The following is a description of a gene set: studied in species Mus musculus Mouse Gene Set: GOBP_COCHLEA_DEVELOPMENT The progression of the cochlea over time from its formation to the mature structure. The cochlea is the snail-shaped portion of the inner ear that is responsible for the detection of sound., and this is the list of marker genes: Ptk7, Grhl3, Hey2, Hpn, Slc17a8 (solute carrier family 17 (sodium-dependent inorganic phosphate cotransporter), member 8), Neurog1, Kcnk2, Pafah1b1, Fgfr3, Vangl2, Grxcr1, Pou3f4, Gabrb3, Pax2, Ccna2, Cecr2, Cdh1, Hoxa1, Sox9, Myo3b, Gabrb2, Dvl3, Gata2 (NCBI Gene Id 14461), Cdh23, Calb1, Slitrk6, Hes1, Zeb1, Dvl2 (NCBI Gene Id 13543), Mcm2, Ocm, Adam10, Six1, Gabra5, Tbx2, Fzd2, Myo7a, Gata3, Tifab, Cthrc1, Kcnq1, Kcnk3, Tbx18, Gli2, Psap, Dchs1, Atp2b2, Sobp, Tbx1, Ift27, Dvl1, Ift88, Eya1, Slc26a5, Rpgrip1l, Tshr, Nectin3, Frzb, Wnt5a, Epha4, Nectin1, Myo3a, Rac1 (Rac family small GTPase 1), Ift20